Given this list of marker genes LYN, PIK3CA, PIK3CB, PIK3CD, SYK, here is a description of the gene set: Human Gene Set: KEGG_MEDICUS_PATHOGEN_EBV_LMP2A_TO_PI3K_SIGNALING_PATHWAY species: Homo sapiens EBV LMP2A to PI3K signaling pathway. Pathway ID: N00266. Pathway type: Pathogen. Pathway class: nt06530 PI3K signaling. Pathway Definition from KEGG: LMP2A -> (LYN,SYK) -> PI3K